Given this list of marker genes Pik3cb, Pik3ca, Pik3cd, Pik3c2a, Pik3c2b, Pik3c2g, Pik3cg, here is a description of the gene set: Mouse Gene Set: GOMF_1_PHOSPHATIDYLINOSITOL_4_PHOSPHATE_3_KINASE_ACTIVITY species: Mus musculus Catalysis of the reaction: a 1-phosphatidyl-1D-myo-inositol 4-phosphate + ATP = a 1-phosphatidyl-1D-myo-inositol 3,4-bisphosphate + ADP + H+.